The following is a description of a gene set: Developmental hypoplasia (shortening) of middle phalanx of toe. species: Homo sapiens Short middle phalanx of toe Human Gene Set: HP_SHORT_MIDDLE_PHALANX_OF_TOE, and this is the list of marker genes: HOXD13, TRPV4, FGFR3, FGFR1, FGFR2